The following is a description of a gene set: A G protein-coupled receptor signaling pathway initiated by an opioid binding to its receptor on the surface of a target cell, and ending with the regulation of a downstream cellular process. species: Homo sapiens Human Gene Set: GOBP_G_PROTEIN_COUPLED_OPIOID_RECEPTOR_SIGNALING_PATHWAY, and this is the list of marker genes: NPBWR2, ITGB3, ADCY8, SYP, PENK, PPP1R9B, SIGMAR1, OPRL1, OPRD1, OPRK1, OPRM1, NPBWR1